Given this list of marker genes RABGAP1, KIF4A, IGLV, VAMP2, STX16, NSF, TUBB3, RAB7B, MAN1C1, AP2A2, RGP1, KIF11, TF, AP3B1, PRKAB2, CHMP2A, KIF2A, GAPVD1, EXOC6, CCZ1B, JCHAIN, WASL, PRKAG3, NAA35, VAMP7, IGHV3-9, VPS37D, SYT2, ANKRD28, EPN1, GABARAP, CHMP6, ASPSCR1, SFN, MAP1LC3B (NCBI Gene Id 81631), REPS2, RIN2, CHMP4C, RAB3IL1, IGHV1-2, MASP1, LDLR, SAR1B, SCOC, COPS4, UBC, CBL, KIFC1, TUBB2B, ADRB2, VPS28, ARFRP1, KIF3B, ACTR3, CYTH4, PIK3C2A, AKT3, COG3, NAPB, KIF1B, CHMP4A, SNAP23, DYNC1I1, GJB5, CHMP3, TRAPPC6B, TSC1, KIF2B, SCARA5, SPTBN5, GOLIM4, COG7, CLTA, CTSC, RACGAP1, VAMP4, IGLV4-3, KIF25, AP2B1, CTSZ, GOLGA4, IGLV2-33, CAPZB, PIP5K1C, IGKV1D-12, DYNC1LI1, RPS27A, DCTN2, DENND5B, ARF6, EPGN, RAB33B, RALGAPA2, AP1S3, TBC1D13, PACSIN2, IGLV6-57, GJB7, SPTBN1, COL7A1, STX10, COPS8, COG4, SCGB3A2, AP1G2, IGLV2-11, AKT2, MON1A, IGHV3-13, RAB1B, TRAPPC10, IGHA2 (NCBI Gene Id 388025), ZW10 (NCBI Gene Id 9183), ACTG1, DNM1, CNIH2, AP2A1, IGKV2D-40, SEC22C, IGLV5-45, BLOC1S4, SEC23A, IGLV5-37, COPS2, SPTA1, GRIA1, TBC1D10B, TRAPPC3 (trafficking protein particle complex subunit 3), HBEGF, CALR, TRAPPC9, ARPC5, SPTBN4, SCARF1, RAB10, GDI2, IGLV1-51, FOLR1 (NCBI Gene Id 2348), ARRB2 (arrestin beta 2), CD4, WNT5A, TRAPPC2, IGF2R, RAB7A, IGLV3-25, DCTN1, IGLV7-43, HBA1, TUBA3E, YWHAZ, RAB3A, STXBP3, DNASE2, VTI1A, KIF5A, GGA3, TGFA, VPS53, IGHV3-30, TRIP10, SLC18A3 (NCBI Gene Id 6572), HPR, IGHV3-11, SYNJ2, USP6NL, DENND1C, F8, TRIP11, VTA1, TPD52, YWHAG (tyrosine 3-monooxygenase/tryptophan 5-monooxygenase activation protein gamma), GBF1, EXOC8, MAN1A2, CD5L, ALB, IGKV2-28, GABARAPL2, SPTB, GALNT1, GGA1, IGLV1-36, TJP1, SYT9, TMED9, STAB1, COPS7B, VPS36, KIFC2, TGOLN2, ARF1, COL4A2, MAN2A1, AP4M1, MYO1C, RAB31, EPN2 (NCBI Gene Id 22905), porB, HPS1 (HPS1 biogenesis of lysosomal organelles complex 3 subunit 1), DENND1A, IGLV1-40, IGKV1D-16, IGKV1-33, PRKAB1, FZD4, RAB38, DENND1B, TUBB6, FCHO2, STAB2, IGLV11-55, CNIH1, TBC1D3, SNF8, DYNC1H1, KIF20A, APOA1, TUBA8, SEC22A, HSP90AA1, IGKV1D-33, TUBB1, KIF16B, IGHV3-53, GCC1, COL3A1, ANK1, TUBA3D, COG6, TRAPPC6A, RAB30, TBC1D10C, RIN3, AP3S1 (adaptor related protein complex 3 subunit sigma 1), RAB33A, RAB11B, TUBA3C, PLA2G6, GOLGA5, ACBD3, CHMP5 (NCBI Gene Id 51612), ALS2CL, PPP6C, TOR1B, DENND2B, ACTR2, RINL, ARF5, IGHV7-81, PRKAG1, EPS15 (epidermal growth factor receptor pathway substrate 15), IGLC6, RAB5C, KIF9 (kinesin family member 9), MARCO, IGHV3-48, S100A9, SNAP91, KIF23, SYS1, SURF4, FTH1, DCTN4, CCZ1, NAA30, RAB27A, LRP1, HPX, IGLV2-18, DENND4A, HPS4, DNAJC6, IGLV2-14, KIF1C, BLOC1S3, IGKV1-12, BLOC1S1, RAB35 (NCBI Gene Id 11021), SEC24A, CD163, KDELR1, STAM, KIF26B, TRAPPC1, GOLGA1, TUBB2A, VAMP8 (NCBI Gene Id 8673), GJD2, MVB12A, SNX18, OPTN, COPG1, DENND4B, HSP90B1, TUBB8, IGLV10-54, COG2, RAB8B, RAB1A (RAB1A, member RAS oncogene family), TUBA4B, EXOC5, MVB12B, TBC1D24, IGKV1-39, MAN1A1, GORASP1, FNBP1L, COPE, VPS45, NAPG, PAFAH1B3, SNX2, KLC2, SYT1, KIF5B, UBQLN1, SORT1, AP1G1, ARPC4, IGKV3-11, IGKC, TUBB8B, IGHV4-34, TUBA1A, GJA10, IGLV3-12, ACTB, DCTN6, RAC1, TSG101, EPS15L1, AP4E1, COL1A1, KLC1, RAB9A (RAB9A, member RAS oncogene family), NECAP2, VPS51, GPS1, GRB2 (growth factor receptor bound protein 2), HP, GJB3, COLEC12, CSNK1D, TFG, TBC1D20, PRKAA2, TRAPPC12, NAA38, GJC1, RAB4A, KIF22, KDELR2, IGLV1-47, IGHV3-23, VPS37C, AP2S1, GALNT2, DYNLL1, RAB36, ARFIP2, IGKV3D-20, FCHO1, STX5, SRC, IGLV3-19, M6PR, SH3D19, TSC2 (NCBI Gene Id 7249), KDELR3, IGLV8-61, SAA1, IGHV1-69, CYTH3, ARL1, INS, TACR1, COPZ1, ACTR1A, ALS2, COPS3, PICALM, CAPZA2, TMEM115, SYT8, STX4, ITSN2, KIF19, SBF1, IGKV1D-39, AP1M2, RALGAPB, PACSIN3, SLC2A8, IGHV2-5, ARF4, SCARB1, IGKV2D-28, UBQLN2, TBC1D1, SH3KBP1, COPS6, GDI1, TBC1D8B, KIF3A, YWHAB, BET1L (Bet1 golgi vesicular membrane trafficking protein like), RABEPK, IGHV3-7, RAB14, MIA2, TUBA1C, EXOC1, OCRL, SEC23IP, IGLV7-46, TUBB4B, EXOC7, LNPEP, CLINT1, SCARB2 (scavenger receptor class B member 2), SH3GL1, TUBAL3, CD3D, MAN2A2, TMED3, AMBP, GJB4, LMAN2L, GJD3, TMED10, SNX5, TMED7, CUX1, IGLV3-22, KIFAP3, CAPZA3, KIF4B, MSR1, SBF2 (NCBI Gene Id 81846), ARFGAP1, UBA52, RHOQ, CD3G, DYNC1I2, KIF12, KIF20B, IGLV4-60, DENND2A, HMGB1 (NCBI Gene Id 3146), STX17, EXOC2, NBAS, IGLV3-16, CLVS2, SSC5D, GJD4, UBAP1, FNBP1, TBC1D4, COPG2, PUM1, EGFR (NCBI Gene Id 1956), SEC13, CHMP7, CD36, COPB1, HSPH1, CHM, PRDX1, BET1, CHRM2, RINT1, SH3GL3, RAB5B, GJC2, RIN1, SGIP1, DNM3, BICD1, RAB3GAP2 (NCBI Gene Id 26114), STON1, USO1, IGLV4-69, IGHV1-46, CPD, SPARC, GAK, GJB1, TRAPPC4, TRAPPC11, DENND3, ARPC1A, SLC2A4, MON1B, CD59, COPZ2, TUBB4A, TBC1D25, RAB9B, RAB21, KIF27, SEC31B, KIF6, AGFG1, VPS52, RAB8A, SPTAN1, SEC22B, IGKV1-17, IGHV2-70, KIF3C, HBB, MIA3, CNIH3, IGLC2, KIF18B, COG5, ALPP, IGKV2-30, HIP1, E, ULK1, SEC16B, CYTH2, AP4B1, ARFGAP3, PACSIN1, AP1B1, IGHV4-59, COPS5, IGKV1-5, COPB2, GJB6, NEDD8, TUBA1B, COG1, TBC1D10A, IGKV4-1, TMF1, TXNDC5, TFRC, USE1, EGF, IGKV5-2, LMAN2, VPS37B, SH3GL2, PPP6R3, IL7R (interleukin 7 receptor), GOLGB1, DENND5A (DENN domain containing 5A), KIAA0319, KIF2C, TRAPPC5, BNIP1, BLOC1S6, STX6, IGLV3-21, VPS4A, MYH9, EXOC3, VPS54, GRK3, GJA4, RIC1, ANKRD27, CENPE, MYO5A, GRK2, DTNBP1, TPD52L1, RAB18, IGHA1, DYNLL2, SYT11, LMAN1L, GJA9, DNM2, RAB3GAP1, COPS7A, APOB, GOSR2, RAB11A, HIP1R (huntingtin interacting protein 1 related), HSPA8, IGKV2-29, STX18, IGLV2-23, AP1S2, AGTR1, KIF15, AP1M1, ARF3, CLTCL1 (clathrin heavy chain like 1), GGA2, TBC1D17, GJA8, HGS, VPS37A, STAM2, SNAPIN, SYTL1, CHMP2B, AP4S1, SEC24D, YWHAE, HYOU1, IGHV, RHOBTB3, RABEP1, YWHAQ, IGHV4-39, TBC1D16, TBC1D15, IGLV2-8, SNX9, TRAPPC2L, IGHV3-33, DCTN3, TBC1D7, KIF28P, TBC1D2, RAB41, SEC16A, SNAP29, UBB, ARFGAP2, YKT6, DENND2C, PLIN3, PLA2G4A, APOL1, BTC, KIF21B, COG8, PREB, RAB39B, CYTH1, TMED2, YWHAH (NCBI Gene Id 7533), COPA, AREG, CHML, AAK1 (NCBI Gene Id 652453), CLVS1, CAPZA1, DCTN5, IGKV3-20, RAB6B, KIF26A, RAB43, IGLV3-1, YIPF6, DVL2, PAFAH1B2, RAB13, ANK3, CHMP4B, RAB3IP, IGLV3-27, COL1A2, TUBA4A, GOSR1, GOLGA2, GCC2, PAFAH1B1, MADD, GJA5, EXOC4, DENND6B, TRAPPC13, SEC24B, RALA, RABGEF1, MYO6, DYNC1LI2, SERPINA1, IGLC1, LDLRAP1, RAB39A, AP2M1, KIF1A, IGLC7, VAMP3, ITSN1, NAPA, TRAPPC8, SEC24C, AKT1, DAB2, POLG, KIF21A, AMPH, C2CD5, AP1S1, BICD2, PRKAG2, RAB12 (RAB12, member RAS oncogene family), VPS25, KIF13B, DENND2D, ARRB1, CFTR, DENND4C, AVPR2, ARPC2, ARPC3, VPS4B, IGKV3-15, ANK2, AVP, GJB2, REPS1, RAB27B, KIF5C, IGKV1-16, KLC4, CTTN, IGLC3, RAB5A, PPP6R1 (protein phosphatase 6 regulatory subunit 1), TBC1D14, COLEC11, MCFD2, ARCN1, CLTC, KLC3, CALM1, TOR1A, BIN1, RAB32, RAB6A, LMAN1, EREG, DENND6A, CD55, IGLV1-44, SEC31A, APOE, LRP2 (NCBI Gene Id 4036), GNS, AGPAT3, SCFD1, FTL, STON2, F5, COL4A1, GJA3, SPTBN2, ACTR10, GJA1, APP, NECAP1, SYNJ1, KIF18A, CLTB, IGKV2D-30, here is a description of the gene set: species: Homo sapiens Reactome Pathway: Vesicle-mediated transport The transit of proteins and other cargo through the cell requires a cellular transport process in which transported substances are moved in membrane-bounded vesicles. Transported substances are enclosed in the vesicle lumen or located in the vesicle membrane. The transport process begins with the formation of the vesicle itself, often triggered by the interaction of the cargo with the vesicle formation machinery. Vesicular transport pathways can include vesicle formation, coating, budding, uncoating and target membrane fusion depending upon the function of the pathway described. Vesicle-mediated transport occurs from within cell via ER and Golgi transport, as well as functioning in the endocytosis of material taken into the cell via scavenger receptors.